Given this list of marker genes TRAF6, PLOD3, PAX7, GRHL3, PKD2, GRHL2, CDK20, RPGRIP1L, SSBP3, MARCKS, VASP, TGIF1, LMO4, NODAL, CECR2, OVOL2, ALDH1A2, IFT122, GLI3, MTHFR, BMI1, WDR19, DLC1, SUFU, BMP4, PTCH1, RALA, ZFP36L1, TWIST1, HIF1A, RGMA, TGFB2, ZEB2, CELSR1, FOXB1, PLXNA2, SMO (NCBI Gene Id 6608), SHH, MIB1, SPINT2, CBY1, IFT140, PKD1, TULP3, EPHA2, SDC4, FKBP8, PAX2, TRAF3IP1, PFN1, NOTCH1, APAF1, FZD6, CC2D2A, CFL1, SEC24B, IFT57, COBL, SLC39A12, SPECC1L, DACT1, PTK7, WDPCP, ABL1, FGF8, SALL4, ADM, INTU, GDF7, WNT1 (NCBI Gene Id 7471), PRICKLE1, CHRD, ARHGAP35, LIAS, GSC, LUZP1, NUP50, FOLR1, KAT5, TEAD2, SEMA4C, C2CD3, WDR83, PSEN1, DZIP1L, LHX2, HES1, KIF20B, GBX2, ITPK1, MED12, SFRP2, TCTN1, OPA1, TTBK2, NF1, TMED2, FUZ, BMP5, PRKACA, ZNF358, BBS4, AMBRA1, DEAF1, RARG, FERD3L, IFT172, ARL13B, GLMN, STK3, IFT52, STK4, SEMA3C, TRIM71, NUP133, MKS1, DVL2, CITED2, STIL (STIL centriolar assembly protein), TGFB1 (NCBI Gene Id 7040), TSC1 (NCBI Gene Id 7248), KDM2B, HES5, KAT2A, MTHFD1, SPINT1, MTHFD1L, RNF220, PLXNB2, TMEM107, CASP3, EN1, VANGL2, FOXA1 (forkhead box A1), DVL1, GPR161 (NCBI Gene Id 23432), SCRIB, CLUAP1, BMP7, RPS7, ST14, TBC1D32 (TBC1 domain family member 32), PHGDH, GLI2, FZD3, SOX17, TSC2, CTHRC1, SKI, PROX1, ATP6AP2, PAX6, PRKACB, NOG, WNT3A, WNT5A, RARA, BRD2, LRP2, ALX1, BCL10, DCHS1, NCKAP1, SFRP1, PHACTR4, here is a description of the gene set: studied in species Homo sapiens Human Gene Set: GOBP_NEURAL_TUBE_DEVELOPMENT The process whose specific outcome is the progression of the neural tube over time, from its formation to the mature structure. The mature structure of the neural tube exists when the tube has been segmented into the forebrain, midbrain, hindbrain and spinal cord regions. In addition neural crest has budded away from the epithelium.